Given this list of marker genes ASXL3, TACR3, MARVELD1, RGS7BP, SPMIP5, here is a description of the gene set: from publication Figueroa ME, Lugthart S, Li Y, Erpelinck-Verschueren C, Deng X, Christos PJ, Schifano E, Booth J, van Putten W, Skrabanek L, Campagne F, Mazumdar M, Greally JM, Valk PJ, Löwenberg B, Delwel R, Melnick A (PMID 20060365) Human Gene Set: FIGUEROA_AML_METHYLATION_CLUSTER_7_DN species: Homo sapiens We hypothesized that DNA methylation distributes into specific patterns in cancer cells, which reflect critical biological differences. We therefore examined the methylation profiles of 344 patients with acute myeloid leukemia (AML). Clustering of these patients by methylation data segregated patients into 16 groups. Five of these groups defined new AML subtypes that shared no other known feature. In addition, DNA methylation profiles segregated patients with CEBPA aberrations from other subtypes of leukemia, defined four epigenetically distinct forms of AML with NPM1 mutations, and showed that established AML1-ETO, CBFb-MYH11, and PML-RARA leukemia entities are associated with specific methylation profiles. We report a 15 gene methylation classifier predictive of overall survival in an independent patient cohort (p < 0.001, adjusted for known covariates). Cluster 7 of aberrantly hypomethylated genes in blasts from AML (acute myeloid leukemia) patients.